Given this list of marker genes LAMA3, GLUL, CPPED1, NEDD4, DPP4, TBX3, H2BC12, SPARCL1, SMYD2 (NCBI Gene Id 56950), RHBG, REG3A, DUT, here is a description of the gene set: from publication Boyault S, Rickman DS, de Reyniès A, Balabaud C, Rebouissou S, Jeannot E, Hérault A, Saric J, Belghiti J, Franco D, Bioulac-Sage P, Laurent-Puig P, Zucman-Rossi J (PMID 17187432) Hepatocellular carcinomas (HCCs) are a heterogeneous group of tumors that differ in risk factors and genetic alterations. We further investigated transcriptome-genotype-phenotype correlations in HCC. Global transcriptome analyses were performed on 57 HCCs and 3 hepatocellular adenomas and validated by quantitative RT-PCR using 63 additional HCCs. We determined loss of heterozygosity, gene mutations, promoter methylation of CDH1 and CDKN2A, and HBV DNA copy number for each tumor. Unsupervised transcriptome analysis identified 6 robust subgroups of HCC (G1-G6) associated with clinical and genetic characteristics. G1 tumors were associated with low copy number of HBV and overexpression of genes expressed in fetal liver and controlled by parental imprinting. G2 included HCCs infected with a high copy number of HBV and mutations in PIK3CA and TP53. In these first groups, we detected specific activation of the AKT pathway. G3 tumors were typified by mutation of TP53 and overexpression of genes controlling the cell cycle. G4 was a heterogeneous subgroup of tumors including TCF1-mutated hepatocellular adenomas and carcinomas. G5 and G6 were strongly related to beta-catenin mutations that lead to Wnt pathway activation; in particular, G6 tumors were characterized by satellite nodules, higher activation of the Wnt pathway, and E-cadherin underexpression. CONCLUSION: These results have furthered our understanding of the genetic diversity of human HCC and have provided specific identifiers for classifying tumors. In addition, our classification has potential therapeutic implications because 50% of the tumors were related to WNT or AKT pathway activation, which potentially could be targeted by specific inhibiting therapies. species: Homo sapiens Human Gene Set: BOYAULT_LIVER_CANCER_SUBCLASS_G56_UP Up-regulated genes in hepatocellular carcinoma (HCC) subclass G56, defined by unsupervised clustering.